The following is a description of a gene set: Human Gene Set: WP_DUAL_HIJACK_MODEL_OF_VIF_IN_HIV_INFECTION species: Homo sapiens Dual hijack model of Vif in HIV infection, and this is the list of marker genes: CBFB, ELOB, UBB, CUL5, APOBEC3G, ELOC, RUNX1, RBX1